The following is a description of a gene set: Human Gene Set: PID_INTEGRIN_CS_PATHWAY species: Homo sapiens from publication Schaefer CF, Anthony K, Krupa S, Buchoff J, Day M, Hannay T, Buetow KH (PMID 18832364) Integrin family cell surface interactions, and this is the list of marker genes: ITGB5, ITGAL, ITGA2, ITGA7, ITGA6, ITGAD, ITGAM, ITGB2, ITGA5, ITGAV, ITGA1, ITGA3, ITGA9, ITGA11, ITGA2B, ITGA10, ITGAX, ITGA4, ITGAE, ITGB6, ITGB4, ITGB1, ITGB8, ITGB7, ITGB3 (integrin subunit beta 3), ITGA8